The following is a description of a gene set: Transcription regulation during the cell cycle is crucial for ensuring genes are expressed at the right time and in the correct amounts, coordinating key processes like DNA replication, mitosis, and cell division. In our study, Transcription factors and DNA binding proteins enriched at promoters of genes whose expression fluctuates during the cell cycle (pVal < 0.05) and peak in the first half of the S phase (S1) in K562 Human Gene Set: PULVER_FOREY_CELLCYCLE_ENRICHED_TFS_S1 studied in species Homo sapiens, and this is the list of marker genes: ZNF100, TFAP4, POLR2A, NRF1, KDM5B, ZNF783, CHCHD3, E2F6, E2F4, MAZ, CTBP1, ZNF776, SAFB, SOX6, RB1, L3MBTL2, EGR3, VEZF1, CHD2, SP4, ZBTB14, ZSCAN29, ZNF534, SMAD5, ARID4B, CXXC5, HMGXB4, TOE1, E2F8, MTA3, PRPF4, NONO, ZFX, HMGN3, ZBTB7A, ZFP64, GLIS1, ZNF282, KLF15, E2F5, HNRNPK, POLR2H, POLR2G, PML, SIN3A (NCBI Gene Id 25942), ZNF761, ZNF639, CREM, THRAP3, RBFOX2, TAF1, ATF1, UBTF, ZBTB1, EGR1 (NCBI Gene Id 1958), ZBTB26, RNF2 (NCBI Gene Id 6045), MGA, AFF4, ELF1, TBP, TFDP1, EP400, HDAC1, HNRNPLL, YY1, ZNF786, POLR2B, CCNT2, SP2, MAX, GMEB1, MNT, SMARCA4, RBBP5, E2F7, ZNF382, ZNF124, E2F1, GABPB1, SUPT5H, EGR2, GTF2F1, REST, FOS, DMTF1, PHF8, SMAD4, MYBL2, FIP1L1, ZNF202, E2F3, ATF7, ZZZ3, ATF6, SP1, MYC (MYC proto-oncogene, bHLH transcription factor), ZNF511